Given this list of marker genes Opn3, Mfsd12, Wnt5a, Slc24a5 (NCBI Gene Id 317750), Rapgef2, here is a description of the gene set: studied in species Mus musculus Any process that stops, prevents or reduces the frequency, rate or extent of secondary metabolite biosynthetic process. Mouse Gene Set: GOBP_NEGATIVE_REGULATION_OF_SECONDARY_METABOLITE_BIOSYNTHETIC_PROCESS